Given this list of marker genes TUT4, YAP1, DPPA4, TP53 (tumor protein p53), DUX4, EP300, KDM4E, CREBBP, ZSCAN4 (zinc finger and SCAN domain containing 4), DPPA2, TEAD4, TPRX1, TUT7, DUXB, TPRX2, LEUTX, DUXA, here is a description of the gene set: Human Gene Set: REACTOME_ZYGOTIC_GENOME_ACTIVATION_ZGA species: Homo sapiens Zygotic genome activation (ZGA)